The following is a description of a gene set: Mouse Gene Set: GOBP_MORPHOGENESIS_OF_AN_EPITHELIAL_BUD The morphogenetic process in which a bud forms from an epithelial sheet. A bud is a protrusion that forms form the sheet by localized folding. studied in species Mus musculus, and this is the list of marker genes: Nog, Pthlh, Rdh10, Wnt2b, Hhex, Fgf10, Ar, Shh, Bmp4, Sostdc1, Sulf1, Fgfr2, Ctnnb1, Wnt2, Bmp7, Trp63 (NCBI Gene Id 22061), Gli2 (NCBI Gene Id 98707), Wnt5a